The following is a description of a gene set: Genes down-regulated in Vd1 gamma delta T cells: LPS versus phorbol myristate acetate and ionomycin. Human Gene Set: GSE3720_LPS_VS_PMA_STIM_VD1_GAMMADELTA_TCELL_DN from publication Kress E, Hedges JF, Jutila MA (PMID 16423401) studied in species Homo sapiens The two major human gd T cell subsets, Vd1 and Vd2, display differences in tissue tropism and agonist responses, but we have little insight into global differences that may exist at the gene expression level. This is due to the small numbers of these cells that can be obtained from healthy donors, which limit comprehensive, comparative gene expression analyses. We established a culture method that expands Vd1 and Vd2 cells from the same PBL preparation to levels sufficient for sorting and microarray analysis. Although the subsets were expanded identically (anti-TCR mAb, plus IL-15), 392 and genes were identified, which were differentially expressed in the two subsets, from two donors, respectively. Approximately genes changed in both subsets following PMA/ionomycin treatment; about 50% of these genes were subset-specific. Both subsets responded to a crude LPS preparation, but only 6% of the responsive genes were the same. The differentially expressed genes were consistent with Vd2 cells being more inflammatory and Vd1 cells having more of a regulatory phenotype. Both subsets expressed transcripts encoding an array of innate and NK cell receptors, supporting the relationship of gd T cells to the innate immune system. Our results show that circulating Vd1 and Vd2 subsets in humans have considerable, inherent differences in gene expression following treatment with non-TCR agonists, supporting unique functional roles for these cells in vivo., and this is the list of marker genes: LYST, PDLIM2, MRPL27, WDR43, TGFBR3, TACC3, RING1, THG1L, NT5C, PSMG1, STAP1, CTPS2, EVL, PSMD12, MCM5, POLQ, TRAF3IP2, YEATS4, GPSM3 (G protein signaling modulator 3), ATP6V0D2, EIF3G, RPL4, PSME1, ITGAX, PDCL3, CARMIL2, THAP3, SHISA9, NOP53, PHF21A, IFI30, RPLP0, EPS8L1, F2RL1, RAPGEF6, ZC3H13, SLAMF6, METTL1, SPAG7, RPL12, ASAH2, ZNF18, UMPS, KLHDC2, RCN3, TRIM59, MNS1, NAA30, RPL23, GIMAP7, SH3BP5, N6AMT1, MIF, PSMB8, PRMT3, TENT5C, CD2, CXCR3, DNAJC19, USE1, CNP, CXXC1, LY6K, MEF2D, TBC1D30, GMFG, RPL18, RPL29, P3H3, XCL1, NR4A3, LARP7, TRMT112, PPDPF, MELK, AIP, COTL1, SGMS1, H4C4, CDIPT, FANCL, CAPN11, PRRG4, NME3 (NME/NM23 nucleoside diphosphate kinase 3), RPL36A, FILIP1L, RPL27, ZNHIT6, NASP, STARD3NL, PGLS, GPR65, GPR132, CLEC3B, ACOT7, ADGRG5, LTB, TNFSF8, EAPP, NFKBIB, TGFB1, MAP3K5, TMSB10, PIGS, CDCA7, ADAM11, EEF1A1, PIK3R5, GPATCH3, MID1IP1, IKBKE, RIN3, UBA2, PDE2A (NCBI Gene Id 5138), GPR183, CCNI, EPHA4 (NCBI Gene Id 401031), RPL10A (NCBI Gene Id 4736), CCT5, SLAIN2, RUFY2, LY6E, MFSD6, NEURL3, SIDT1, GRAMD2B (GRAM domain containing 2B), CD3D, KLF13, DGAT2L6, CLTA, CD55, NFE2L2, DPP4, MYC (NCBI Gene Id 731404), RNASEH2C, RPL3, FAM162A, MPC2, KBTBD11, RPS26, CHMP4B, EMB, EOMES, FAU, PLEKHA1, LEPROTL1, H4C14, NDUFV3, CCR3 (NCBI Gene Id 1232), ZYG11B, H2AZ2, MRPL2, TRIO, MAD2L1, KTN1, PGLYRP1, RPS10, TRPM2, SATB1, VAMP7, BOLA3, SELL, RPSA, DOK2, LSM4, PSME2, COX5A, RPS14, CALM2, POLR2M, EEF1B2, FZD1